Given this list of marker genes CALHM2, CALHM1, CALHM4, CD47, CALHM6, CR1, ANKH, SLC17A9, CALHM5, CALHM3, here is a description of the gene set: The directed movement of ATP out of a cell or organelle. Human Gene Set: GOBP_ATP_EXPORT species: Homo sapiens